Given this list of marker genes Arg2, Padi3, Padi4, Padi2, Ddah1, Padi1, Allc, Ddah2, Arg1, Agmat, Padi6, here is a description of the gene set: Catalysis of the hydrolysis of any non-peptide carbon-nitrogen bond in a linear amidine, a compound of the form R-C(=NH)-NH2. studied in species Mus musculus Mouse Gene Set: GOMF_HYDROLASE_ACTIVITY_ACTING_ON_CARBON_NITROGEN_BUT_NOT_PEPTIDE_BONDS_IN_LINEAR_AMIDINES